Given this list of marker genes Slc25a13, Aspg, Got2, Aspa, Folh1, Gadl1, Nat8l, Slc25a12, Naalad2, Asns, Got1, here is a description of the gene set: species: Mus musculus Aspartate and asparagine metabolism Mouse Gene Set: REACTOME_ASPARTATE_AND_ASPARAGINE_METABOLISM